Given this list of marker genes IFIH1, RTF1, MBL2 (mannose binding lectin 2), CTR9, EXOC1, CLEC5A, DENCMEMSB, PAF1, IKBKE, VTN, C1QA, APOA1, UBR4, STING1, CLU, HSP90AB1, TRIM25, C4BPB, DDX3X, C4A, HSP90AA1, LEO1, RBM10, CGAS, CDC73, C4B, SKIC8, STAT2 (NCBI Gene Id 6773), C1S, C4BPA, MAVS, PML, here is a description of the gene set: part of: Dengue Virus-Host Interactions studied in species Homo sapiens Reactome Pathway: Dengue virus activates/modulates innate and adaptive immune responses Dengue virus nonstructural protein NS1 interacts with several parts of the complement system. In addition, nonstructural proteins, as well as prM and C, bind factors of the host's type I interferon antiviral response. The overall picture is known from many expression studies. For general reviews about DENV subversion of innate immunity see Kao et al., 2018; Tremblay et al., 2019; Carr et al., 2020; Kraivong et al., 2021; Pan et al., 2022. DENV also employs various strategies to evade the adaptive immune system, including antigenic variation and inhibition of antigen presentation.